The following is a description of a gene set: Under conditions of cellular stress, nuclear levels of phosphatidylinositol-5-phosphate (PI5P) increase and, through interaction with ING2, result in nuclear retention/accumulation of ING2. ING2 binds TP53 (p53) and recruits histone acetyltransferase EP300 (p300) to TP53, leading to TP53 acetylation. Increased nuclear PI5P levels positively regulate TP53 acetylation. part of: Regulation of TP53 Activity through Acetylation studied in species Homo sapiens Reactome Pathway: PI5P Regulates TP53 Acetylation, and this is the list of marker genes: EP300, PIP4K2B (NCBI Gene Id 8396), ING2, PIP4K2C, MAP2K6, TP53, PIP4K2A, PIN1, PIP4P1